The following is a description of a gene set: studied in species Mus musculus Mouse Gene Set: GOMF_ENZYME_INHIBITOR_ACTIVITY Binds to and stops, prevents or reduces the activity of an enzyme., and this is the list of marker genes: Serpina5, Gapdh-ps15, Ppp1r12a, Serpinb6a, Limk1 (LIM domain kinase 1), Gpc3, Prkar2b, Ywhab, Birc6, Hspa5, Nherf4, Spint1, Socs3, Hsp90b1 (heat shock protein 90, beta (Grp94), member 1), Gnai1, Inka1, Rpl23, Ppp4r4, Serpinb3d, Gm28729, Cst13, Serpina3g, Oaz3, Csta3, Uchl5, Tprn, Serpinb9e, Eppin, Ctla2b, Dus2, Prkar2a, Oaz1, Sh3bp5l, Serpinb6e (NCBI Gene Id 435350), Pde6d, Ppp1r10, Ccar2, Ugt1a8, Slit2, Spink7, Rptor, Parp9 (poly (ADP-ribose) polymerase family, member 9), Phactr4, Atad3a, Timp3, Furin (NCBI Gene Id 78149), Otub1 (NCBI Gene Id 107260), Serpina3i, Ibtk, Cast, Serpina11 (serine (or cysteine) peptidase inhibitor, clade A (alpha-1 antiproteinase, antitrypsin), member 11), Cdkn1c, Spint3, Csn2, Serpinb13, Smcr8, Tmx1, Tesc, Spock3, Rcan1, Akt1, Mansc4, Pot1a, Tfpi, Smr2, Cit, Wfdc17 (WAP four-disulfide core domain 17), Pebp1, Spint4, Gbp2, Pkig, Ppp1r14bl, Gbp5, Kat2b, Stfa1, Bsn, Pak1ip1, Kng2, Serpina1f, Gapdhrt, Ppp1r12c, Rps20, Wdtc1, Cdkn2d, Rarres1, Dusp22, Dynll1, Serpinb9, Ppp1r2, Rps15, Wfikkn1, Itih3, Trib2, Cstdc1, Ankrd42 (ankyrin repeat domain 42), Ugt1a9, Wnk1, Mug2, Serpina3a, Smo, Prkar1a, Xiap, Wfdc13, Naip1, Cdkn1b (cyclin dependent kinase inhibitor 1B), Hrg, Serpinb1b, Fry, Mrln, Styx-ps, Serpinb2, Serpinb3a, Serpinb9g, Serpinb6d, Spink4, Serpinb9c, Ankle2, Timp2, Ppp1r16b (protein phosphatase 1, regulatory subunit 16B), Mgat5, Smtnl1, Gckr, Ngf, Gnaz, Sirpa, Smr3a, Serpina1d, Styxl1, Gprc5b, Ppp1r14c, Hspb1, Inka2, Scg5, Gbp4, Mug1, Tiprl, Hexim2, Spink8, Serpina1e, Bod1, Angptl3, Gskip, C4b, Ppp1r16a, Tmem225, Ppp1r14b, Timp1, Gchfr, Glmn, Serpinb10, Cdkn2a, Snca, Ugt1a7c, Spink2, Cst8, Serpinb9d, Ppp1r1b, Pinx1, Serpinb12, Scgb1a1, Cstl1, Ensa, Acd, Simc1, Wfdc21, Socs5 (suppressor of cytokine signaling 5), Pcsk1n, Grm7, Pmp22, Csta1, Serpini1, Serpinb6b, Wfdc6b, Parva, Stfa2, Ptp4a2, Serpina3b, Pzp, Itih4, Sh3bp5, Cst9, Tescl, Wfikkn2, Rpl5, Wfdc12 (NCBI Gene Id 192200), Spink5, Chp1, Prkar1b, Hexim1, Ppp1r26, Anp32e, Cdkn1a, Serpinb3c, Fetub, Serpinb1a, Serpinb3b, Spink11, Spry2, Apoa2, Serpina1a, Trib3 (NCBI Gene Id 23913), Wfdc5, Gapdh, Prkrip1, Ppp1r36, Ppef2, Ppp2r5a, Fbxo5, Abce1, Col7a1, Usp14, Serpina16, Inca1 (NCBI Gene Id 216875), Cib1, Col28a1, Lrrk2, Serpina3j (NCBI Gene Id 278628), Ppp1r1c, Cstdc6, Serpina1b, Lilrb4b, Cpeb2, Bst2 (NCBI Gene Id 97478), Myoz1, Pabir1, Serpinb9f, Stfa2l1, Prkag2, Dtx3l, Ppp1r12b, Itih2, Cst5, Notch1, Rtkn, Cstdc4, Ppp1r14d, Socs1, Faf2, Ten1 (NCBI Gene Id 69535), Ambp, Elfn1, Pi16, Cd55, Psmf1, Ppp1r17, Lilrb4a (leukocyte immunoglobulin-like receptor, subfamily B, member 4A), Crb2, Thbs1, Serpinb9b, Rgs2, Wfdc15b (WAP four-disulfide core domain 15B), Prnp, Pinlyp, Pabir2, Inhca, Ngp, App, Wfdc3, Serpina10, Kdm5a, Serping1, Pot1b, Dgki, Dnajc3, Serpina3c, Serpini2, Cdkn2c, Camk2n1, Npm1, Prkch, Kng1, Ppp1r8, Serpinc1, Serpina3m, Wap, Birc7, Itprip, Cstdc5, Pkib, Arpp19 (cAMP-regulated phosphoprotein 19), Serpinf2, Prex1, Camk2n2, Gbp2b, Cstdc3, Apoc2, Serpinb6c, Cstb, A2ml1, Spink13, Serpinb7, Crim1, Agt, Dusp19, Elfn2, Spink1 (serine peptidase inhibitor, Kazal type 1), Slpi, Pbp2, Stfa3, Spink10, Wars1, Htra2, Anxa1, Rack1, Deptor, Prex2, Timp4, Ppp1r1a, Serpine1, Apba3, Flcn, Ski, Rps7, Apoc2l, Cst11, Gapdhrt2, Reck (reversion-inducing-cysteine-rich protein with kazal motifs), Spint2, Spred2, Igfbp2, Wfdc18, Trib1, Apoa1, Serpine3, Cep43, Gmppa, Sh3rf2, Pif1, Ptprc, Cd55b, 2810408A11Rik, Styx (NCBI Gene Id 80592), Ppp1r35 (protein phosphatase 1, regulatory subunit 35), Atp2b4, Sorl1, Nlrp2, Renbp, Tfpi2, Ywhae, Dffa (NCBI Gene Id 13347), Ptn (NCBI Gene Id 19242), Itih1, Serpina6, Qars1, Hnrnpc, Wfdc16, Anxa3, Spry4, Serpina9 (serine (or cysteine) peptidase inhibitor, clade A (alpha-1 antiproteinase, antitrypsin), member 9), C3 (complement component 3), Hyal2, Serpina3k, Cry2, Spink12, Rnh1, Serpine2, Birc5, Wfdc8, Phactr1, R3hdml, Ppp1r27, Ugt1a10, Serpina7 (NCBI Gene Id 331535), Lxn, Serpinb11, Serpina3f, Wfdc1, Ugt1a1, Macroh2a1, Serpinb1c, Serpinh1, Umodl1, Spred1, Angptl4, Cst7, Nck1, Papln, Txnip, Wfdc9, Apoc3, Pttg1, Wfdc15a, Cav1, Lmtk2, Rpl37, Rpl11, Ltf, Serpina12, Casp3 (NCBI Gene Id 12367), Serpinb5, Park7, Tsacc, Spink6 (NCBI Gene Id 433180), Wfdc6a, Serpinb9h, Aplp2, Ezhip, Tmbim6, Uri1, Apoc1, Cd109, Cmya5, Oaz2, A2m, Csta2, Serpina3n, Serpinb8, Smr2l, Ppp1r37, Serpina1c, Col6a3, Wfdc10, Oas1d, Pi15 (peptidase inhibitor 15), Lrp6, C1qbp, Anxa2, Ppp1r9b, Cdkn2b, Mbip, Bin1, Rhoh, Dgkz, Sumf2, Rpl37rt, Ppp1r11, Sbf1, Ucn, Wfdc11, Ahsg, Cip2a, Clstn3, Ppt1, Gm7298, Adgrv1, Cst3, Phactr3, Itih5, Cabin1, Cst12, Hc, Spock1, Arrb1, Ppp1r14a, Wfdc2, Mcrs1, Nolc1, Serpinf1, Serpind1, Pkia, Calu, Akt1s1